Given this list of marker genes Fpr-rs7, Ninj1, Nod2, Ecm1, Ptafr, Aif1, Defb25, F7, Ccl2, Dapk2, Mospd2, Myd88, St3gal4, Plcb1 (NCBI Gene Id 98861), Pla2g7 (phospholipase A2, group VII (platelet-activating factor acetylhydrolase, plasma)), Tnfaip6, Madcam1, Spi1, Wnk1, Stap1, Slamf8, Il4, Bcr, Ccl19-ps4, Fpr-rs6, Gpr15lg, Gcnt1, Calr, Ptk2b, Nckap1l, Cx3cr1, Cd74, Ptpn22, Swap70, Il33, Pycard, Gp1ba, Akirin1, Gdf15, Nf1, Lgals3, Perp, Pdgfd, Mmp9, Lyve1, Mdk, Adora1, Ifnb1, Ccl21a, Hc, Edn1, Stk39, Msn, Rac2, Trem2, Aire, Dnm1l (NCBI Gene Id 74006), Ccl21b, Itga2, Ccl25, Fpr-rs3, Cxcl10, Stk10, C5ar2, Lgals9, Adam10, Il12a, Ccl1, Fpr-rs4, Selenok, Cd69, Gcsam, Ccl28, Il23a, Fut9, Nedd9, Mia3, Gpsm3 (G-protein signalling modulator 3 (AGS3-like, C. elegans)), Hmgb1, Zfp580, Nbl1, Adam17, Csf1, Mcu, Med23, Spn, Ada, Ccl20, Wnt5a, Cd81, Rhoa, Ccl24, Csf1r, Rin3, Cx3cl1, Dpp4, Tlr2, Mtus1, Oxsr1, Mmp14, Slit2, Chst2, Cd300a (CD300A molecule), Chst4, Mst1, Abl2, Ccn3, Tnfsf14, Pgf, Edn2, Ccl21d, Rac1, Ccl12, Ano6, P2rx4, Emilin1, Cxcl14, Lgmn (NCBI Gene Id 19141), Camk1d, Cd200r1, Vegfb, Ccl21e, Coro1a, Fut7, Cxcr3 (NCBI Gene Id 12766), Grem1 (NCBI Gene Id 23892), Dysf, Cxcl13, Zp3, Sell, Icam1, Jam2, Mpp1, Lyn, Ppbp, Ccl19-ps3, P2ry12, Ccl19-ps5, Wasl, Cd9, Abr, Ripor2, Ager, Cxcl12, Mmp28, Adtrp, Slc8b1 (solute carrier family 8 (sodium/lithium/calcium exchanger), member B1), Adora3, C1qbp, C5ar1, Cxcr2, Ccl21f, Smpd3, BC037156, Itgb3, Thy1, Pik3r1, Ptn, Creb3, Ccr1l1, Sele, Fut4, Mif, Itga2b, Abl1, Tgfb1, Rabgef1, Bst1, Fadd, Kitl, Gpr18 (NCBI Gene Id 263515), Ccr6, Vegfa (NCBI Gene Id 22339), Vegfd (vascular endothelial growth factor D), Il1b, Padi2, Slamf1, Klrk1, Ptger3, Cd99l2, Tnfrsf18, Ccl19, C3ar1 (NCBI Gene Id 12267), App, Mapk1, Vegfc, Pawr, Ccl5, Ptk2, Elane, Dusp1, Ccr7, P4hb, Tirap, Aoc3, Cd47, Serpine1, Pecam1, Cmklr1, Hoxa7, Itga4, Selp, Lbp, Apod, Cxcl17, Mapk3, Trpv4, S100a14, Adam8, Crkl, Myo1f, Lrch1, Tmem102, Cnn2, Plvap, Crk, Ccl19-ps6, Trem1, Ccl19-ps1, Ednra, Ptger4, Mstn, Spns2, Tnfsf4, Rtn4, Ccl7 (NCBI Gene Id 20306), Cd200, Ccr1, Bdkrb1, Tnfsf18, Ascl2 (achaete-scute family bHLH transcription factor 2), Thbs4, Ccl3, Tacr1, Ripk3, Gas6, Edn3 (endothelin 3), Dock8, Rac3, Il1r1, Anxa1, Akt1, Fpr2, Capn1, Cyp19a1, Il27ra, Rarres2, Ccr2 (C-C motif chemokine receptor 2), Xcl1, Ptprj, Trp53, Thbs1, Tnfrsf14, F2rl1, Jam3, Il34, Il1a, here is a description of the gene set: studied in species Mus musculus Any process that modulates the frequency, rate, or extent of leukocyte migration. Mouse Gene Set: GOBP_REGULATION_OF_LEUKOCYTE_MIGRATION